The following is a description of a gene set: A process that results in the assembly, arrangement of constituent parts, or disassembly of a postsynaptic specialization, a structure that lies adjacent to the cytoplasmic face of the postsynaptic membrane. Human Gene Set: GOBP_POSTSYNAPTIC_SPECIALIZATION_ORGANIZATION studied in species Homo sapiens, and this is the list of marker genes: CRIPT, LILRB2, SHANK1, ZMYND8, GAP43, CNTNAP1, ABI3, FGFR1, INSYN1, NPTX1, NRXN1, SLC30A1, CRK, PTPRS, RAPSN, NTNG2 (netrin G2), C1QL3, PPFIA2, C1QL2, ABL1, CNKSR2, OPHN1, LRRTM2, LRRC4, ITGB3, NLGN1, NTRK3, CBLN1, LRFN1, PTEN, TMEM108, CFL1, LRRC4B, NLGN2, CRKL, SYNGAP1, ZDHHC12, SPTBN2, LRFN4, SHANK3, ARHGEF9 (NCBI Gene Id 23229), CDH2, GRID2, GIT1, PRICKLE1, LATS1, SLITRK3, IL1RAP, RELN, CSMD2, NRXN2, PTPRD, CASKIN1, DLG1, PTK2B, ARF6